The following is a description of a gene set: part of: Cell death signalling via NRAGE, NRIF and NADE studied in species Mus musculus Reactome Pathway: NRIF signals cell death from the nucleus electronically inferred by orthology from the curated human pathway This event has been computationally inferred from an event that has been demonstrated in another species.<p>The inference is based on the homology mapping from PANTHER. Briefly, reactions for which all involved PhysicalEntities (in input, output and catalyst) have a mapped orthologue/paralogue (for complexes at least 75% of components must have a mapping) are inferred to the other species., and this is the list of marker genes: Rps27a, Psen1, Psenen, Ubb, Ngfr (nerve growth factor receptor (TNFR superfamily, member 16)), Itgb3bp, Ngf, Sqstm1